Given this list of marker genes KCNQ1OT1, MAP3K1, SOX9, PDE11A, BRCA2, USF3, GREM1, POLE, MLH1, MCC, MAD1L1, FGFR3, STAR, DHX37, IGF2, IDH1, MXI1, TGFBR2, CHEK2, COL14A1, ZFTA, CREBBP, MBD4, CDKN1B, FGFR2, COL4A5, NAB2, RAD51C, ZFHX3, ATM, EPHB2 (EPH receptor B2), COL4A6, PALB2, KEAP1, RAD51D, KRAS (NCBI Gene Id 3845), PTCH1, FH, PTPN12 (NCBI Gene Id 5782), APC2, MRE11, DHH, NR0B1, NBN, MC2R, BRCA1, KANSL1, AR, BUB3, OPCML, KLLN, BARD1, RNF43, MDM2, NSD1, CDKN1C, PTEN, MLH3, TLR2, RAD54B, PLA2G2A, STK11, WT1, AURKA, MSH2, PDGFRL, VAMP7, SEMA4A, PTPRJ, NR5A1, NNT, BAX (NCBI Gene Id 581), STAT6, TRIP13, BUB1B, CDC73, NRAS, PIK3CA, MNX1, CTNNB1, AAGAB (NCBI Gene Id 79719), BMPR1A (bone morphogenetic protein receptor type 1A), GATA4, PTCH2, ZFPM2 (NCBI Gene Id 56958), HNF1B, BCL10, EP300, SRY, SDHD, EWSR1, WWOX, SPRED1, SMAD4, KCNQ1, BRAF, SUFU, PMS1, KIT, VHL, COQ6, FLI1, WNT10A (Wnt family member 10A), IDH2 (NCBI Gene Id 3418), CCND1, KLF6, MUTYH, SLC6A17, BUB1, CDKN2A, FOXE1, SDHC, APC, MSH3, BRIP1, TP53, SETBP1, AKT1, MSH6, PRKAR1A, RAD50, STAG3, PALLD, DICER1, MRAP, PRKN, PAX6, STS, SRC, RAD51, LMNA, AXIN2, ERBB2, DLC1, PMS2, SMARCB1, SEC23B, CDH1, POLD1, RABL3, LZTR1, RNASEL, TXNRD2, DOCK8, WRN (NCBI Gene Id 7486), RPS20, CEP57, EPCAM, FLCN, CYP11B1, NF2, SDHB, NTHL1, DCC, here is a description of the gene set: A tumor (abnormal growth of tissue) of the genital system. Genital neoplasm Human Gene Set: HP_GENITAL_NEOPLASM studied in species Homo sapiens